Given this list of marker genes WIPF1, VASP, DBN1, PCLO, EVL, CTTN, HTT, ACTG1, ENAH, RHOQ, here is a description of the gene set: species: Homo sapiens Binding to profilin, an actin-binding protein that forms a complex with G-actin and prevents it from polymerizing to form F-actin. Human Gene Set: GOMF_PROFILIN_BINDING